The following is a description of a gene set: Genes predicted to be targets of miRBase v22 microRNA mmu_miR_7655_5p in miRDB v6.0 with MirTarget v4 prediction scores > 80 (high confidence targets). Mouse Gene Set: MIR_7655_5P studied in species Mus musculus from publication Chen Y, Wang X (PMID 31504780), and this is the list of marker genes: Pum3, Shoc2, Stab1, Dgkd, Ugcg, Mrrf, Ttf2, Trpm1, Asph, Bcl10, Rbm14, Zmym3, Frrs1, Arfip2, Tmem127, Slc9a8, Robo3, Rnf4, Apc2, Ccnyl1, Reps2, Reep6, Gpam, Rnf217, Lrrc23, Ccdc88a, Adat1, Igbp1, Cep135 (NCBI Gene Id 381644), Hnmt, Lrtm2, Cog2, Cited2, Ncam1